Given this list of marker genes Mocs3, Ctu2, Trmu, Lias, Mocs2, Tstd3, Nfs1, Mpst, Tst, Mocos, here is a description of the gene set: species: Mus musculus Mouse Gene Set: GOMF_SULFURTRANSFERASE_ACTIVITY Catalysis of the transfer of sulfur atoms from one compound (donor) to another (acceptor).